The following is a description of a gene set: The highly related mammalian Sin3A and Sin3B proteins provide a versatile platform for chromatin-modifying activities. Sin3-containing complexes play a role in gene repression through deacetylation of nucleosomes. Here, we explore a role for Sin3 in myogenesis by examining the phenotypes resulting from acute somatic deletion of both isoforms in vivo and from primary myotubes in vitro. Myotubes ablated for Sin3A alone, but not Sin3B, displayed gross defects in sarcomere structure that were considerably enhanced upon simultaneous ablation of both isoforms. Massively parallel sequencing of Sin3A- and Sin3B-bound genomic loci revealed a subset of target genes directly involved in sarcomere function that are positively regulated by Sin3A and Sin3B proteins. Both proteins were coordinately recruited to a substantial number of genes. Interestingly, depletion of Sin3B led to compensatory increases in Sin3A recruitment at certain target loci, but Sin3B was never found to compensate for Sin3A loss. Thus, our analyses describe a novel transcriptional role for Sin3A and Sin3B proteins associated with maintenance of differentiated muscle cells. Human Gene Set: VANOEVELEN_MYOGENESIS_SIN3A_TARGETS Loci bound exclusively by SIN3A in myotubules. from publication van Oevelen C, Bowman C, Pellegrino J, Asp P, Cheng J, Parisi F, Micsinai M, Kluger Y, Chu A, Blais A, David G, Dynlacht BD (PMID 20956564) studied in species Mus musculus, and this is the list of marker genes: CAB39L, UCHL3, PPP2R2A, NSUN3, NDOR1, DAP3, FAM114A2, ZNF607 (zinc finger protein 607), ZBTB5, ARHGAP33, PMM2, RPS9, RAE1 (ribonucleic acid export 1), PPP2R3C, CAMK2A, ERF, IDH3A, KGD4, PHKB, ETFB, CDH6, EDA2R, TRPV2, CLCN3, TBCA, APPL2, VAMP3, BTD, SDC1, PFKL, FTL, COLGALT1 (collagen beta(1-O)galactosyltransferase 1), MED15 (mediator complex subunit 15), SLC7A6OS, PHF5A, BLZF1, CHTF8, ANXA5, DUSP7, SCLT1, HSP90B1, KIAA1191, LIF (NCBI Gene Id 3976), DUSP10, SUCLG2 (succinate-CoA ligase GDP-forming subunit beta), KANK2, RIC8A, RPS24, TOMM34, HACD3, NFIL3, TXNRD1, TFB1M, MTRF1L, TJP1, GNPTAB, RIPOR1, GTPBP2, VAMP4, VPS35, PIK3IP1, COA5, CCT5, C6orf226, NPPB, MXI1, MBTD1, GNS, NMD3, NAP1L4, ZDHHC20, SIPA1L1, SLC12A9, ZNF189, GPC5, SUPT6H, ENOPH1 (NCBI Gene Id 58478), VSIR, NDRG1, GNG5, STK19, WWP2, HAX1, VMP1, ST6GAL1, TRMT6, E2F6, TAB3, MINK1, DTL, BTBD6, C1orf131, ANKRD13B, PTPN1, AHCY, COQ10B, HP1BP3, FAM53B, ARHGAP22, URB2, RCN1, NLN, MCTP2, ZCCHC24, DUSP2, GNL2, ATP6V1A, ACTR1B, ING5, VPS52, MSANTD4, ANKRD26, CREB1, GEMIN5, PARPBP, RNF13 (NCBI Gene Id 11342), ZNF248, CLCN5, LPCAT3, THOC3, RHBDD2, HOXC8, PRXL2C, ARPC1B, CIART, SLC39A3, GON7 (NCBI Gene Id 84520), FBXL8, PARG, SURF2, PTDSS2, TERF2IP, POLR1G, CHCHD4, CEP68, CNPPD1, PRRG4, NOP16, MTNAP1, BBS5, USP5, ERGIC3, LDLR, TBC1D24, MZT1, CMAS, HIPK2, ABI2, PPP1R11, FHIT, MRPS16, BAZ1A, CCDC71, RPSA, HMOX1, OGN, IQCB1, CTU2, ASXL1, CKS1B, SLC35A5, ERGIC1, PBLD, ABCC5, BCL2L11, MRPL57, TMCO3, FLII, ABHD6, HMGA1, PMS2, PIBF1, NRM, OLA1, DCLRE1B, TSEN54, SERF1A, DDX51, SOD2, RALA, SORCS2, GFER, NOA1, PACC1, SLC25A40, SCAMP2 (NCBI Gene Id 10066), RARA, POP7, RAD51AP1, MLYCD, COA7, LMLN, RPP38, MYO6, LIN28A, ARHGAP5, RIOX2, N6AMT1, DPP3, GPANK1, PGLS, DPAGT1, RNF114, HS2ST1, MFSD5, PPP3CB, TAC4, DCTD, OGFOD2, MRPS33, KIF17, PNPLA6 (NCBI Gene Id 10908, patatin like phospholipase domain containing 6), RNF181, SH3GL1, SSTR1, EIF2B1, ZNF667, CEP85, PKP4, LRIG1, ZWILCH